Given this list of marker genes AKR1B10 (NCBI Gene Id 9405), CYB5R2, GLUD1, LARP1, ZNF512B, CTAGE1, ZFPM2, PDZD2, FGF2, ITPK1, PHF24, HOXC10, SEPTIN5, COL12A1, SLC7A6, SLC18A2, ACSS1, PLEKHM3, ESR1, STX17, RNF185, MAPRE2, ZNF189, AIG1, CHEK1, SHISA7, CHD2 (chromodomain helicase DNA binding protein 2), DENND1C, PPP6R2, RALA, AKR1B15, TBCD, ADAMTS1, KSR2, HADHA, MOSMO, PPP6R3, MYO1E, DAG1, CHAD, SUSD6, SORCS1, KRT37, CHMP1A, ZZZ3, BEX5, ZMYND11, CLDND1, LASP1, STXBP6 (NCBI Gene Id 29091), RIMS3, SRGAP2 (NCBI Gene Id 440748), HM13, PSAP, THAP11, CYB561A3, DCX, TADA2B (NCBI Gene Id 93624), ASIC1, CTNND1, CAV1, PABPN1, CCL8, SYNGR1, SLC46A2, MAGEL2, CNNM4, ABHD4, TAP2, IRF2BP2, PPP2CA, SLC6A16, here is a description of the gene set: Human Gene Set: MIR4733_3P from publication Chen Y, Wang X (PMID 31504780) Genes predicted to be targets of miRBase v22 microRNA hsa-miR-4733-3p in miRDB v6.0 with MirTarget v4 prediction scores > 80 (high confidence targets). studied in species Homo sapiens